The following is a description of a gene set: species: Homo sapiens Human Gene Set: GOBP_CARBOHYDRATE_TRANSPORT The directed movement of carbohydrate into, out of or within a cell, or between cells, by means of some agent such as a transporter or pore. Carbohydrates are a group of organic compounds based of the general formula Cx(H2O)y., and this is the list of marker genes: AQP1, SLC2A4, SLC1A2, OSTN, AQP7, ERFE, INS (NCBI Gene Id 3630), MIR107, TSC1, SLC26A5, ARPP19, MIR103A1, FFAR4 (free fatty acid receptor 4), SLC23A2, SLC2A9, SLC2A1, POU4F2, CD2AP, MIR223, APPL2, PIK3R1, EDNRA, PRKCB, AKT2, MFSD2A, C2CD5, AQP9, MEF2A (myocyte enhancer factor 2A), SLC5A2, SLC2A12, CREBL2, SLC2A3, SLC45A2, AQP2, PTH, OPN3, PPBP, PTPRM, SLC2A8, AQP10, RTN2, CLIP3, MIR143 (NCBI Gene Id 406935), SMPD3, RAP1A, DRD1, SLC17A5, SESN2, SLC25A27, SIRT6, OCLN, IL1B, SLC5A10, INSR, TNF, CAPN10 (calpain 10), LEP, IRS1, SLC27A1, ZDHHC7, ITLN1, PEA15, RNASEL, EDN1, AQP11, MFSD2B, ENPP1, IGF1, ASPSCR1, SLC2A6, STXBP4 (NCBI Gene Id 337994), SLC2A7, MAPK14, TRARG1, AQP7B, C1QTNF12, STXBP3, SLC50A1, TRIB3, SLC5A3, RSC1A1, MFSD12, ACACB, SORBS1, NFE2L2 (NCBI Gene Id 4780), IRS2, TMEM144, YES1, SLC23A1, SLC2A10, GRB10, CLTCL1, PPARD, FGF19, GH1, GSK3A, TERT, SLC5A11, SLC2A11, AQP3, RAB4B, ADIPOQ, GPC3, HK2, NR4A3, SLC45A4, BRAF, SLC2A5, SLC2A14, SELENON, AKT1, SLC27A4, SLC2A2, RHOQ, PLA2G1B, KLF15, HNF1A, PRKAG2, SELENOS (NCBI Gene Id 55829), SLC45A1 (NCBI Gene Id 50651), FABP5, SORT1, OSBPL8, SLC26A6, CTNND1, APPL1, C3, FGF21, SGCB, PTPN11, CERS1, INPP5K, PID1, SLC5A1, SLC45A3, PRKCI, DHRS7C, SLC5A9